The following is a description of a gene set: A chromatin remodeling process that allows DNA repair enzyme to access genomic DNA and repair DNA lesions. studied in species Homo sapiens Human Gene Set: GOBP_DNA_REPAIR_DEPENDENT_CHROMATIN_REMODELING, and this is the list of marker genes: SIRT7, APLF, TRIP12, HDGFL2, PARP2, BABAM1, BRCC3, HPF1, PHF1, HDAC3, DTX3L, KDM1A, USP51, UBR5, SIRT1, SIRT6, RNF8, UIMC1, TRRAP, USP3, ASF1A, RNF168, KAT5